Given this list of marker genes SACM1L, SBF1, PI4K2B, PI4KA, MTMR2, here is a description of the gene set: species: Homo sapiens Human Gene Set: REACTOME_SYNTHESIS_OF_PIPS_AT_THE_ER_MEMBRANE Synthesis of PIPs at the ER membrane